The following is a description of a gene set: Mouse Gene Set: REACTOME_MISCELLANEOUS_TRANSPORT_AND_BINDING_EVENTS Miscellaneous transport and binding events species: Mus musculus, and this is the list of marker genes: Ank, Slc66a1, Nipa1, Lrrc8a, Csn3, Magt1, Lrrc8d, Azgp1, Nipal4, Csn1s1, Add3, Add2 (adducin 2), Dmtn, Nipal3, Mrs2, Lrrc8e, Tusc3, Lrrc8c, Nipal2, Ctns, Add1, Lrrc8b, Gm28035, Nipa2, Pip, Nipal1